Given this list of marker genes TRIM40, PRPS2, PPL, ABHD17B, VIM, EGR2, S100A6, CYLD, FAH, OSM, JUN, STK3, LARP4, CCND2, ADGRL2, HS3ST2, KDELR2, LITAF, PSENEN, DMXL2, TNFRSF1B (TNF receptor superfamily member 1B), MAPRE3, ALS2, DUSP5, LINC01160, SLC38A2, TP53I13, SIRPA, MCOLN2, FHIP1A, GAS7, RNF13, AHNAK2, NFIL3, H6PD, RAB29, POU2AF2, CASP4, CD86, PCMTD1, PPP1R3G, PRKCA, GBP7 (NCBI Gene Id 388646), CCR5, PRKAR2A, CMA1, TG, SYPL1, PHLPP1, VWA5A, TPD52, MYADM, ZBTB20, EPS8, FXYD5, CISH, STX11, CPEB2, MGMT, MAP4K5, PMEPA1, AHR, ZBTB32, RPL30, MREG, SPCS3, B4GALT1, ZNF281, PTGER4, PPP1R16B, ADM, LGALS1, PLAC8, YPEL2, RAB31, SBNO2, B4GALT6, HK2 (hexokinase 2), TAGLN2, JMY, NACC2 (NACC family member 2), SERTAD2, AFDN (NCBI Gene Id 92217), CD274, UBASH3B, SPTY2D1, LIFR (LIF receptor subunit alpha), CXCL2, TIPARP (NCBI Gene Id 25976), BCO2, ZEB2, NPC2, SORCS2 (sortilin related VPS10 domain containing receptor 2), CD9, TPPP3, NR3C2, CMC1, TBC1D9, CYTIP, TMEFF1, ART3, RBM47, RCN3, TMEM106A, FOSL2, SLC17A9, CTLA4, EPCAM, LIPA (NCBI Gene Id 3988), PLEKHA1, BATF (basic leucine zipper ATF-like transcription factor), ANKRD33B, PDE8A, PARD3B, PIM1, ELL2 (elongation factor for RNA polymerase II 2), ITGA6, GLS (glutaminase), ACBD4, IER3, HDC, ID2, LSM12, CD69, MAPK6, NEUROD4, CLVS1, ASPH, KRT222, ANKS1B, ACTN1, SLC35F5, HHAT, TMEM176B, GPX7 (NCBI Gene Id 91407), UPB1, PRRT1, AHNAK, TCF4, GEM, PFKFB3, TRIO, STK38, CDKN2D, MAN2A2 (NCBI Gene Id 55485), HEPACAM2, SH3BGRL2, CXCL3, STX7, TUB, SCAMP1, GIMAP4, SEMA3B, PRR5L, SLC7A7, SH3RF1, MDFIC, FCGR2B, PSTPIP2, MACIR, NID1, PEPD, PIM2, CRIP1, CSF2RB, FGL2, EIF1, GNB3, CCR9, MGST1, PRDM1, RRP1B, SOS1 (NCBI Gene Id 7838), FAM241B, S100A10, GPR137B, FLOT1, PTK2, KCNC1, CHST7, TTC33, CPNE3, IL5RA, TWSG1, HIPK3, TENT5C, CCR1, IL6ST, ARID5A, NIPA2, OOSP2, GBP2, INPP4A, STK24, IL10, DIRAS2, CD300LF, RESF1, TRIB1, CDH17, here is a description of the gene set: Differentially expressed genes of CD11b+Gr-1+ immature myeloid cells (IMCs) in the bone marrow and colonic tumor setting of histidine decarboxylase (HDC)-KO mice were examined by microarray (Affymetrix Mouse 430.2 array). Myeloid differentiation-related candidate genes were sought to be isolated and functionally studied. Genes up-regulated in myeloid-derived suppressor cells: bone marrow versus colon tumor. studied in species Homo sapiens Human Gene Set: GSE23502_BM_VS_COLON_TUMOR_MYELOID_DERIVED_SUPPRESSOR_CELL_UP from publication Yang XD, Ai W, Asfaha S, Bhagat G, Friedman RA, Jin G, Park H, Shykind B, Diacovo TG, Falus A, Wang TC (PMID 21170045)